Given this list of marker genes PSMD12, ALOX5, GNS, MMP9, HUWE1, CALML5, YPEL5, EEF1A1, FTH1, COTL1, JUP, COMMD9, PSMA5, ATG7, MAPK14 (mitogen-activated protein kinase 14), DDX3X, TNFAIP6, ALAD, CTSD, HSPA8, ARPC5, DYNLT1, HK3, MAPK1, CTSS, ALDOC, VCL, MNDA, CTSH, AMPD3, PSMD11, CDK13, CSTB, FGL2, COMMD3, CFD, PSMB1 (proteasome 20S subunit beta 1), CSNK2B, CAPN1, XRCC6, QPCT, PSMC2 (NCBI Gene Id 5701), GSN, NME2, SERPINA1, PSMB7 (NCBI Gene Id 5695), PGAM1, PSMD7, CANT1, HSP90AA1, HSP90AB1, ACTR10, AGL, PRDX4, GSTP1, HSPA1A, ACTR2, PPIE, DBNL, APEH, CTSZ, PLEKHO2, ACLY, CCT8, GLB1, PNP, PSMD2, PSMD3, GUSB, PPIA, CAB39, A1BG, PGM1, PGM2, HBB, PSMD6 (proteasome 26S subunit, non-ATPase 6), PSMD13, ILF2, KRT1, GYG1, IDH1, PDAP1, KCMF1, PAFAH1B2, FCN1, SRP14, PSMA2, MVP, BIN2, DERA, CRISPLD2, VCP, ALDOA, MIF, HSPA6, ASAH1, OSTF1, C1orf35, GSDMD, ACTR1B, TIMP2, PRG2 (NCBI Gene Id 87065), KPNB1, LTA4H, CAND1, GMFG, EEF2, GPI, PKM, CST3, HSPA1B (NCBI Gene Id 3304), PYGL, IMPDH2, LRG1, CDA, PSMC3, ARSB (NCBI Gene Id 411), IMPDH1, PSMD14, APAF1, PFKL, CTSB, HMGB1, CAT, here is a description of the gene set: studied in species Homo sapiens Human Gene Set: GOCC_FICOLIN_1_RICH_GRANULE_LUMEN Any membrane-enclosed lumen that is part of a ficolin-1-rich granule.